The following is a description of a gene set: Glomerulonephritis studied in species Homo sapiens Inflammation of the renal glomeruli. Human Gene Set: HP_GLOMERULONEPHRITIS, and this is the list of marker genes: ALMS1, DNASE1L3, NUP160, PLCE1, TNFSF4, NUP133, FCGR3B, DAAM2, NUP37, DGKE, EMP2, ARHGAP24 (Rho GTPase activating protein 24, NCBI Gene Id 83478), TAPBP, MECP2, C1QA, ITGAM, HLA-DRB1, MME, IRF5, TREX1, KLRC4, COL4A3, SMARCAL1 (NCBI Gene Id 50485), HLA-DPB1, CCR1, FAS, C4A, SOX18, DNASE2, STAT4, TRIM8, IL12A-AS1, NUP85, IL12A, NPHS1, PRTN3, CD81, PDCD1, FCGR2A, IL6, CD2AP (CD2 associated protein), LACC1, LMX1B, MIF, FASLG, NPHS2, ERAP1, IGHG1, CASP10, CFHR5, ZAP70, TRPC6, ARHGDIA, COL7A1, ZNFX1, UBAC2 (NCBI Gene Id 94902), TLR7, CTLA4, IFNGR1, WT1, TNFAIP3, KIAA0319L, SOCS1, MEFV, PTPN22, NUP205, CRB2, HLA-B, C3, CR2, NUP107, JAZF1, GAPVD1, FCGR2B, BANK1, APOL1, NUP93 (nucleoporin 93), LAGE3, MAGI2, COPA, BLK, IRAK1, TNIP1, LAMB2, ANLN, TLR4 (NCBI Gene Id 7099), LMNB2, SLC7A7, IL10, SPP1, ACTN4, KIRREL1, DNASE1, WDR19, PTPRO, CFI, IL23R, PGM3, INF2, FOXP3 (forkhead box P3), KANK2, PXK, PAX2, UBE2L3, PRKCD, ANKFY1, JAK1, SLC37A4, MYO1E, TBC1D8B, ETS1, HLA-DPA1, ARPC5, MMP1, COQ8B, C4B